Given this list of marker genes Rasgrp3, Hras, Rasgrp1, here is a description of the gene set: Reactome Pathway: Activation of RAS in B cells species: Mus musculus electronically inferred by orthology from the curated human pathway part of: Downstream signaling events of B Cell Receptor (BCR) This event has been computationally inferred from an event that has been demonstrated in another species.<p>The inference is based on the homology mapping from PANTHER. Briefly, reactions for which all involved PhysicalEntities (in input, output and catalyst) have a mapped orthologue/paralogue (for complexes at least 75% of components must have a mapping) are inferred to the other species.